Given this list of marker genes IMPG2, NR6A1, MYH1, BACH1, OVOL1 (NCBI Gene Id 5017), KRT25, SIAH3, ATP6AP2, RPL34, ATXN7L1, RNF39, BCL6, STX7 (NCBI Gene Id 8417), CS, IRX2-DT, MLLT10 (NCBI Gene Id 8028), FOXB1, TUBB4A, CDKN2C, FEZF2, DAAM2, BAMBI, LIX1, TMEM185A, SLC44A3 (solute carrier family 44 member 3), HCRT, ADRA1A, NTRK1, PURA (NCBI Gene Id 5813), NEO1, LRRTM1, TTF2, PPM1E, FOXP2, HOXC12, NPR3, ELF4, DMD, DMRTA1, LMO1, BMP1, NKX2-1, PLEKHA6, PLPP1, LINC00311, SFRP1, LINC01565, BASP1, ADAMTS17, MS4A1, ZIC4, UBE2E4P, FOSB, HNF1A, CACNB3, PRND, PAX8, NFIB, RASL10B, KCNQ1DN, DIXDC1, NEBL, SLITRK1 (NCBI Gene Id 114798), HOXC4, DLX1, LTBP3 (latent transforming growth factor beta binding protein 3), LHX5, BARHL2, C8A, RCAN1, PRKACA, THRA, PDZRN4, DNAJB4, MSTN, WNT10A, OTP, CDH9, U2AF2, OTX2, AP1S2, ZFP36L1, RPL34-DT, GNAO1, CHST8, SEMA6C, SEZ6L, FGF19, MITF, HERPUD2, AFF3, LPAR4, ZNF423, HOXB7, MAP2K5, ROBO3, PCDH18, ZFHX4, CGN, YPEL4 (NCBI Gene Id 219539), RP1L1, AGAP3, PAX6, ALKBH5 (alkB homolog 5, RNA demethylase), PCDH9, PROK2 (prokineticin 2), SUCLG2, KAT6B, DNAJB8, SHOX2, NEUROG1, TFAP2B, SEMA5B, WNT5A, FRA10AC1, TXNL4B, VLDLR, EN1, ZIC1, TBC1D20, NDUFA4L2, CDH20, PDC, ATP5MC1, SSH2 (slingshot protein phosphatase 2), GRM5, GPRC5C, ASIC1, PTPRG (NCBI Gene Id 5793), VSNL1, NDST4, DNAJC5B, CNN3, SP7, KCNK2, SLC37A4, LINC01164, FYN, NDNF, MTUS1, USP44, FIGN, LRFN5, FZD7, PIK3R3, GRHL1, ARHGAP36, SKIDA1, VAMP8, OGT, CHRNA2, DDX6, RAPGEFL1, WDPCP, LSM12, DHX38, PHOX2B, SYNE2, TMEM178A, PRPF38B (NCBI Gene Id 55119), CA2, RGS12, PITX1, LDB2 (LIM domain binding 2), BTBD3, FLRT3, KCNMA1, ADD3, GPR158, SLC26A7, WNT3A, TLE4, MED24, IRX4, LINC02875, SLC7A9, CDH6, MAOA, SND1, CYFIP2 (cytoplasmic FMR1 interacting protein 2), RHBDL3, RTN4RL1, NPVF, FOXF2, POGZ, MAP4, LMO3, FBXO40, MYBPC2, IRX2, CASK, ATP2B4, LBX1, OTOP3, GAP43, GPC3 (NCBI Gene Id 6394), PRL, PPP1R16A (protein phosphatase 1 regulatory subunit 16A), SACM1L, DLG2, C22orf31, ELMO2, RBP3, PRRX1, PPP1R1B, PRKAB1, MSX1 (NCBI Gene Id 4487), NOL4L, LUC7L3, POU4F3, PXDC1, NLGN2, PLXNA2, NR2F1, FILIP1, POU2F1, H2AZ1, PITX2, NFIL3, HESX1, BACE2, SLC24A2, CGA, GJD2, RPP25, ETV1, BMP4, BHLHE41 (basic helix-loop-helix family member e41), here is a description of the gene set: Genes having at least one occurrence of the motif NNNTAATTAGCNNN in the regions spanning 4 kb centered on their transcription starting sites. This matches the VSX1 transcription factor binding site V$CHX10_01 (v7.4 TRANSFAC). Human Gene Set: CHX10_01 species: Homo sapiens